The following is a description of a gene set: Mouse Gene Set: GOBP_ENDODERM_DEVELOPMENT species: Mus musculus The process whose specific outcome is the progression of the endoderm over time, from its formation to the mature structure. The endoderm is the innermost germ layer that develops into the gastrointestinal tract, the lungs and associated tissues., and this is the list of marker genes: Dusp1, Foxa2, Pelo, Mmp14, Gdf3, Ext1, Dab2, Nog, Hsbp1, Grb2, Pax9, Sox7, Angpt2, Angpt4, Mesp1, Hdac1, Itga5, Map2k1, Ssbp3, Col11a1, Arc, Cdc73, Dusp5, Epb41l5, Mmp2, Setd2, Sox2, Itgav, Nr0b1, Nanog, Fn1, Smad2, Ctr9, Col12a1, Tnrc6c, Gdf1, Paf1, Wnt8a, Col6a1, Leo1, Pou5f1, Nkx2-1, Rtf1, Dusp4, Col4a2, Bmp4, Tnrc6a, Kif16b, Col5a1, Nkx2-5, Lhx1, Med12, Sox17, Smad4, Smad3, Mmp15, Brd3, Lama3, Fgf8, Mmp8, Notch1, Hmga2, Dusp2, Bmpr1a, Onecut1, Col8a1, Dkk1, Macroh2a1, Inhba, Hhex, Pthlh, Zfp36l1, Gata4, Eomes (eomesodermin), Vtn, Ctnnb1, Angpt1, Mmp9, Ankrd17, Gata6, Bptf, Lamb3, Col5a2, Tgfb1, Mixl1, Nodal, Smim43 (NCBI Gene Id 100503068), Cfc1, Apela, Myh9, Hnf1b, Otx2, Nckap1